Given this list of marker genes ADAR, CORO1C, CDK5RAP3, ADARB1, NPM1, here is a description of the gene set: Human Gene Set: GOBP_NEGATIVE_REGULATION_OF_PROTEIN_KINASE_ACTIVITY_BY_REGULATION_OF_PROTEIN_PHOSPHORYLATION The stopping, prevention, or reduction in frequency, rate or extent of protein kinase activity as a result of regulating the phosphorylation status of that protein kinase. species: Homo sapiens